The following is a description of a gene set: Mouse Gene Set: GOBP_PLATELET_DENSE_GRANULE_ORGANIZATION A process that is carried out at the cellular level which results in the assembly, arrangement of constituent parts, or disassembly of a platelet dense granule. A platelet dense granule is an electron-dense granule occurring in blood platelets that stores and secretes adenosine nucleotides and serotonin. They contain a highly condensed core consisting of serotonin, histamine, calcium, magnesium, ATP, ADP, pyrophosphate and membrane lysosomal proteins. species: Mus musculus, and this is the list of marker genes: Hps3, Hps6, Ap3s2, Dtnbp1 (dystrobrevin binding protein 1), Hps5, Hps4, Ap1s3, Ap1m1, Ap1g1, Ap3m1, Ap3b1, Ap1s1, Ap3s1, Ap1s2, Abca1 (ATP-binding cassette, sub-family A member 1), Slc35d3, Ap1b1, Hps1, Rab38, Bloc1s3, Ap3d1